The following is a description of a gene set: Any process that modulates the frequency, rate or extent of the chemical reactions and pathways involving catecholamines. Mouse Gene Set: GOBP_REGULATION_OF_CATECHOLAMINE_METABOLIC_PROCESS studied in species Mus musculus, and this is the list of marker genes: Drd4, Park7, Epas1, Vhl, Prkn, Maob, Aldh2, Comt, Drd1, Itgam, Gpr37, Atp7a, Htr1a (5-hydroxytryptamine (serotonin) receptor 1A), Hprt1, Pnkd, Slc6a3, Snca, Npy, Chrnb2, Htr2c, Vps35 (VPS35 retromer complex component), Abat, Tacr3, Nr4a2